The following is a description of a gene set: species: Mus musculus Mouse Gene Set: GOBP_NMDA_SELECTIVE_GLUTAMATE_RECEPTOR_SIGNALING_PATHWAY The series of molecular signals initiated by glutamate binding to an NMDA-selective glutamate receptor on the surface of the target cell, followed by the movement of ions through a channel in the receptor complex, and ending with the regulation of a downstream cellular process, e.g. transcription., and this is the list of marker genes: Grin2b, Gm527, Dlg4, Tiam1, Kalrn, Camk2a, Mef2c, Nrxn1